Given this list of marker genes D130043K22Rik, Pum2, Tnr, Ntrk3, Lrp1, here is a description of the gene set: studied in species Mus musculus Mouse Gene Set: GOBP_REGULATION_OF_SPROUTING_OF_INJURED_AXON Any process that modulates the frequency, rate or extent of sprouting of an injured axon.